The following is a description of a gene set: GLP-1 in pancreatic islet cells Human Gene Set: WP_GLP1_IN_PANCREATIC_ISLET_CELLS studied in species Homo sapiens, and this is the list of marker genes: INS, IL6, SLC2A1, GLP1R, IL6R, GCG, SLC2A2